Given this list of marker genes Slc25a19, Akr1a1, Nfkb1, Slc19a3, Rfk, Cyp2r1, Vkorc1, Snai1, Thtpa, Cyp27b1, Ugt1a6a, Ubiad1, Gfi1, Gulo, Cyp27a1, Slc19a2, Tpk1, Akr1b1, Tnf, Pdxk, Pnpo, Snai2, Ifng, Rgn, Pltp, Gsto1, Cyp24a1, here is a description of the gene set: The chemical reactions and pathways resulting in the formation of a vitamin, one of a number of unrelated organic substances that occur in many foods in small amounts and that are necessary in trace amounts for the normal metabolic functioning of the body. species: Mus musculus Mouse Gene Set: GOBP_VITAMIN_BIOSYNTHETIC_PROCESS